Given this list of marker genes PRIM1, RFC1, POLA1 (NCBI Gene Id 5422, DNA polymerase alpha 1, catalytic subunit), RFC2, RFC4, POLD1, POLD2, RFC3, POLA2, PRIM2, PCNA, POLD4 (NCBI Gene Id 57804), RFC5, POLD3 (NCBI Gene Id 10714), here is a description of the gene set: After the primers are synthesized, Replication Factor C binds to the 3'-end of the initiator DNA to trigger polymerase switching. The non-processive nature of pol alpha catalytic activity and the tight binding of Replication Factor C to the primer-template junction presumably lead to the turnover of the pol alpha:primase complex. After the Pol alpha-primase primase complex is displaced from the primer, the proliferating cell nuclear antigen (PCNA) binds to form a "sliding clamp" structure. Replication Factor C then dissociates, and DNA polymerase delta binds and catalyzes the processive synthesis of DNA. part of: Lagging Strand Synthesis; Leading Strand Synthesis species: Homo sapiens Reactome Pathway: Polymerase switching